Given this list of marker genes ENDOV, RAD50, DNASE2, EXO1, DFFA, XRCC1, TREX2, DNASE1L2, ANKLE1, MBD4, TATDN1, SLX1B, FEN1, MUS81, RAD9A, AEN, EME2, N4BP2, C1QBP, APEX1, ZRANB3, ASTE1, POLE, DCLRE1A, DYNLL1, EME1, APLF, EXO5, DICER1, RAD51C, RAG1, ISG20, XRCC3, MAP1S, REXO2, EXD2, POLG, PLD3, RAD1, DNASE2B, TREX1, RBBP8, POLD1, DNA2, ENDOG, ERCC5, DNASE1, DFFB, MGME1, DCLRE1C, FAN1, BIVM, RPS3, APEX2, SETMAR, APTX, TEFM, ERCC1 (NCBI Gene Id 2067), PLD4, DCLRE1B, MEIOB, GEN1, EXOG, ERCC4, MRE11, NME1 (NME/NM23 nucleoside diphosphate kinase 1), SLX1A (SLX1 homolog A, structure-specific endonuclease subunit), DNASE1L1, DNASE1L3, here is a description of the gene set: Catalysis of the hydrolysis of ester linkages within deoxyribonucleic acid. species: Homo sapiens Human Gene Set: GOMF_DNA_NUCLEASE_ACTIVITY